Given this list of marker genes Stx3, Fabp3, Snca, Hnf4a, Pparg, Cyp4f14, Cyp4a14, Alox5ap, Gpr31b, Tmem175, here is a description of the gene set: Binding to icosatetraenoic acid, any straight-chain fatty acid with twenty carbon atoms and four double bonds per molecule. species: Mus musculus Mouse Gene Set: GOMF_ICOSATETRAENOIC_ACID_BINDING